The following is a description of a gene set: Genes up-regulated in at day 0 B cell wildtype versus CD40L and IL-2 IL-4 IL-5 stimulated at day 3 B cell wildtype. Human Gene Set: GSE46606_UNSTIM_VS_CD40L_IL2_IL5_DAY3_STIMULATED_BCELL_UP species: Homo sapiens from publication Ochiai K, Maienschein-Cline M, Simonetti G, Chen J, Rosenthal R, Brink R, Chong AS, Klein U, Dinner AR, Singh H, Sciammas R (PMID 23684984) Temporal analysis of B cell activation in vitro using CD40L and IL-2/4/5 cytokines in wild type Irf4+/+ B cells or in mutant Irf4-/- B cells harboring a tet-inducible allele of Irf4. IRF4 expression was restored, or not, in the Irf4-/- background by culturing in the presence of low or high concentrations of doxycycline. The results provide insight in the role of IRF4 expression levels in coordinating different programs of B cell differentiation., and this is the list of marker genes: FAM117B, SLC16A10, USP3, BSCL2, C5orf47, SLC24A1, YPEL1, ASF1A, GDE1, ADAM22, H2AC25 (NCBI Gene Id 92815), SMYD3, SPTBN1, TOB1, YPEL3, SIRT5, LIX1L (limb and CNS expressed 1 like), GLCCI1, HMGCL, DYNC1I2 (dynein cytoplasmic 1 intermediate chain 2), C14orf132, IL22RA1, GLRX, KDM5B, BAZ2B (NCBI Gene Id 29994), CCNG2, SPATA7, IL7R, EYA1, ARHGEF28, SPA17, NUSAP1, CACNA1E, MARF1, TREX1, CAT, ROGDI (rogdi atypical leucine zipper), FOXO3, H2BC5, BMF, RBM43, PRR14, ENSG00000291006, GM2A, WFDC1, FAM200C, SPARCL1, SLC24A3, GUSBP4, CUTALP, PGBD2, SH3PXD2A, TMT1A, WDR72, ARB2A, RFPL1, PBX1 (PBX homeobox 1), OTUD1, WBP1L, SLC35E2B, PDE3B, NOA1, PPM1H, NCF2, ARRDC3, GALC, KSR1, UQCRC2, PCBP2, NBR1, CBLB (Cbl proto-oncogene B), ENPP2 (ectonucleotide pyrophosphatase/phosphodiesterase 2), PIK3CG, JAKMIP2, PCYOX1 (NCBI Gene Id 63081), NCOA2, ZNF688, TRIM22, LMO4, LAMC1, FHL2 (four and a half LIM domains 2), TLE4, H2AC6, SEPSECS, ENPP3, RCOR3, KIAA1217, FAM167A, NOVA1, EHMT2 (NCBI Gene Id 80735), CLDN4, RGS2, SPIN2A, EIF3F, TRIM68, CABLES1, CTDSPL, LPIN1, ZNF226, CERS3, MED13L, STAT2, APOLD1, VPS53, ZNF506, AHRR, SLC9A9, ATPSCKMT, LAPTM4A, ERCC6, SYT1, ALAD, SURF1, CFAP20DC, TMEM9, THAP10, TXNIP, TOP2B, TP53INP1, MANBA, NREP, TRPM6, NIFK-AS1, ZNF362, NAP1L2, GFPT2, FRS2, RDM1, ACTR10, PPP2R5C, ZFYVE1, LZTS2, RFX5, TMEM42, EZH1, KCNMB4, TNS3, PROK2, HSD17B11, HEXIM2, PGLYRP4, DNASE2, PRSS30P (serine protease 30, pseudogene), SCN3A, DHRS4-AS1, KLHDC2 (NCBI Gene Id 23588), PROKR2, TNFRSF11A (TNF receptor superfamily member 11a), DLG3, DPYSL2, FMO5, ASB16-AS1, CSRNP2, PHLPP1, VPS35L, GPR155, MAST4, TSPYL4, LAX1, ENSG00000284691, BUB1, F2RL2, KLF7 (KLF transcription factor 7), CBX2, BRD8, LNX2, HERC2, MARVELD2 (NCBI Gene Id 404087), BTN3A2, ADAMTS20, PRUNE2, TMEM44-AS1, FRAT1, MEGF6, RTP4, DNTTIP1, AKR1C1, DCP1B, SCAMP1-AS1, RNF114, UBE2QL1, KIF20A, CSF1, SUPT20H, LIPT2-AS1, TMEM19, PLXNA2, PECAM1, KCNK9, SERTAD4, APBA2, ZFP36, HOXB3, MTARC2 (mitochondrial amidoxime reducing component 2), FBN1, ENTPD1